Given this list of marker genes DLST, SDHB, CDKN2B, GNAS, SDHC, SLC25A11, PRKAR1A, CDKN2C (NCBI Gene Id 654235), MDH2, SDHD, SDHA (succinate dehydrogenase complex flavoprotein subunit A), SDHAF2, MEN1, TMEM127, CDKN1A, NF1 (NCBI Gene Id 646021), MAX, RET, VHL, CDKN1B, FH, KIF1B, here is a description of the gene set: Abnormal circulating calcitonin concentration Human Gene Set: HP_ABNORMAL_CIRCULATING_CALCITONIN_CONCENTRATION studied in species Homo sapiens Concentration of calcitonin, a 32-amino acid polypeptide hormone that is produced primarily by the parafollicular cells of the thyroid, in the blood circulation outside of normal limits.